The following is a description of a gene set: Activation of caspases through apoptosome-mediated cleavage Human Gene Set: REACTOME_ACTIVATION_OF_CASPASES_THROUGH_APOPTOSOME_MEDIATED_CLEAVAGE studied in species Homo sapiens, and this is the list of marker genes: CASP7, CASP3, CYCS, CASP9, APAF1, XIAP